The following is a description of a gene set: Genes down-regulated in squamous cell carcinoma (SCC) compared to normal skin. Chemical induction of squamous tumors in the mouse skin induces multiple benign papillomas: high-frequency terminally benign low-risk papillomas and low-frequency high-risk papillomas, the putative precursor lesions to squamous cell carcinoma (SCC). We have compared the gene expression profile of twenty different early low- and high-risk papillomas with normal skin and SCC. Unsupervised clustering of 514 differentially expressed genes (P<0.001) showed that 9/10 high-risk papillomas clustered with SCC, while 1/10 clustered with low-risk papillomas, and this correlated with keratin markers of tumor progression. Prediction analysis for microarrays (PAM) identified genes that distinguished the two papilloma classes, and a majority of these had a similar expression pattern in both high-risk papillomas and SCC. Additional classifier algorithms generated a gene list that correctly classified unknown benign tumors as low- or high-risk concordant with promotion protocol and keratin profiling. Reduced expression of immune function genes characterized the high-risk papillomas and SCC. Immunohistochemistry confirmed reduced T-cell number in high-risk papillomas, suggesting that reduced adaptive immunity defines papillomas that progress to SCC. These results demonstrate that murine premalignant lesions can be segregated into subgroups by gene expression patterns that correlate with risk for malignant conversion, and suggest a paradigm for generating diagnostic biomarkers for human premalignant lesions with unknown individual risk for malignant conversion. studied in species Mus musculus Human Gene Set: DARWICHE_SQUAMOUS_CELL_CARCINOMA_DN from publication Darwiche N, Ryscavage A, Perez-Lorenzo R, Wright L, Bae DS, Hennings H, Yuspa SH, Glick AB (PMID 17525749), and this is the list of marker genes: PACSIN2, ZNF787, DYNLT2B, ACTA2, TRBV4-1, CALM2, TTC9, SAR1A, IGHG1, SRF, LGALS2, LYAR, ANKEF1, COQ8A, KRTAP6-1, DCTN1, KCNU1, SLC35B1, CALCOCO1, MAP1LC3A, MAP6 (microtubule associated protein 6), INAVA, FAM186A, PPP1R27, LMOD2, OGFOD2, QPRT, HAMP, BAG6, ACTL6B, YTHDF2, SPATA31D1 (NCBI Gene Id 389763), EML4, DIP2A, PABPC4, ACAD9, GTF2I, C16orf90, TLCD3B, BRF1, PLA2G10, GSTZ1, FAM217A, SCN1B, COX19, EBF2, NUF2, OTUD1, TCTE1, VPS37A, OVOL2, C11orf58 (chromosome 11 open reading frame 58), TUBA8, CX3CR1, C14orf119, UBE4B (NCBI Gene Id 10277), DGUOK, LTB4R, WDR70, AKIRIN2, SSU72, TREM2, NPTXR, FAM3A, SMIM11, CCT6B, PHF2, MGAT1 (alpha-1,3-mannosyl-glycoprotein 2-beta-N-acetylglucosaminyltransferase), CP, GID8, CHCHD5, IL17A, PEX16, RPAIN, TMEM144, RACGAP1, BBLN, PYGO2, SELENOT, GNAO1, BRSK2, IRAK1, COL20A1, TYRO3 (TYRO3 protein tyrosine kinase), TRAF2, KRTAP5-2, CSPP1, SOX5, TNP2, HMBOX1, APOD, LHX3, BHLHE22, DENR, PEPD, CENPC, TNFRSF25, SWAP70, GBA1, IFT20, TEX48 (testis expressed 48), CHST11, STRAP, PRRC1, MEF2C, PTPRJ-AS1, TRPC6, SMU1, LRRC58, ACTG2, KPRP, CA3, CFAP144, CPA5, ATP6V0D1 (NCBI Gene Id 9114), ABHD14B (abhydrolase domain containing 14B), RBM12, AFF3, BATF3, SPC24, CLEC3B, SRSF1 (NCBI Gene Id 650453), PATJ, MEOX2, LGMN, CCL27, BCL2A1, RTN4R, CCNI, IL36A, AMBRA1, NIT1, ITPR1, RNF26, SLC39A13, MYO1A, RSPO1, POLI, HOMER3, FAM178B, CDS1, TSSK6, SFN, GTF2E2, SIGLEC5, MRPL19, PAQR7, MAPK8IP3, APOE, PVT1, NBN, RPS3A, RTRAF, ART5, PDXDC1, LRIF1, KRT2, GADD45GIP1, GRIP1, ACSBG1, PKHD1, MED17, ANP32A, SERPINB4, EIF5A, ASNS, TSC22D4 (NCBI Gene Id 94778), GABARAPL2, MYCN, MSI1, DOK4, ARMC9, ZNF830, SPAG5, APP, FOXL2, PDP2, CALML5, FBRSL1 (fibrosin like 1), PUS10, TPM3, ACTA1, ARHGAP4